The following is a description of a gene set: studied in species Mus musculus Mouse Gene Set: RAO_BOUND_BY_SALL4 Murine embryonic stem (ES) cells are defined by continuous self-renewal and pluripotency. A diverse repertoire of protein isoforms arising from alternative splicing is expressed in ES cells without defined biological roles. Sall4, a transcription factor essential for pluripotency, exists as two isoforms (Sall4a and Sall4b). Both isoforms can form homodimers and a heterodimer with each other, and each can interact with Nanog. By genomewide location analysis, we determined that Sall4a and Sall4b have overlapping, but not identical binding sites within the ES cell genome. In addition, Sall4b, but not Sall4a, binds preferentially to highly expressed loci in ES cells. Sall4a and Sall4b binding sites are distinguished by both epigenetic marks at target loci and their clustering with binding sites of other pluripotency factors. When ES cells expressing a single isoform of Sall4 are generated, Sall4b alone could maintain the pluripotent state, although it could not completely suppress all differentiation markers. Sall4a and Sall4b collaborate in maintenance of the pluripotent state but play distinct roles. Our work is novel in establishing such isoform-specific differences in ES cells. from publication Rao S, Zhen S, Roumiantsev S, McDonald LT, Yuan GC, Orkin SH (PMID 20837710) Loci bound by both isoforms (a and b) of SALL4 in ES cells (embryonic stem)., and this is the list of marker genes: Klf2, Vmn2r43, 1700019D03Rik, Vmn2r42 (NCBI Gene Id 22310), Gcm1, Zfp42, Idh1, Spry2, Map4k4, Mzf1, BC030500, Etfrf1, Tbx20, Fgfr1, Tpd52, Sema4b, Trp53, Mtmr12, Gtf3c6, Tmem64, Zfp27, Kifc3, Asns (asparagine synthetase), Myot, Rax, Slc39a14, Slc25a1, Or1j11, Wtap, Zcchc7, Rnf13, F2rl1, Kcmf1, Lmbrd2, Mob4, Ephx2, Tmprss11d, Slc5a1, D630039A03Rik, Vmn1r179, Insyn2b, Or10u3, Zscan10, Or4c31, Chd2, Fn1 (fibronectin 1), Susd6, Trim34a, Zdhhc14, Bcat1, Upp1, Hnrnpa2b1, Sf3b4, Cwf19l2, Jarid2, Aard, Srsf11, Nptx2, Cmklr2, Ccdc141 (coiled-coil domain containing 141), Zfp608, Nkx2-2, Cobl, Gpm6a, Prl7c1, Arnt, Xrn2, Aebp2, Tmeff1, Prdx6, Mib2 (mindbomb E3 ubiquitin protein ligase 2), Ssbp3, Wee1, H2bc11, Itga1, Rhob, Gjb3, Irf2bpl, Cep112, Klhl5, 2410137M14Rik, Insig2, Ywhag, Zfp182 (NCBI Gene Id 319535), Abt1, Hsd17b11, Zfp991, Reep3, Dkk1, Ptgfrn, Zfp704 (zinc finger protein 704), Adipor2, Tmem220, Sox2, Ubr5, Spic, Casq2, Arhgef18, Rptor, Trp53bp1, Sulf2, Ttc39b, Tlk1, Matr3, Chd7, H2ac22, Cfh (NCBI Gene Id 192290), Gcnt2, Aurkb, Ccn2, Uhrf2, Zc3hav1, Vmn2r34, Grsf1, Dgkh, Plin2, Gna13, Whamm, Syncrip, Fryl, Trim2, Usp48, Msantd2, Map10, Klhl34, Lyrm1, Zfp459, Abhd17b, Ccdc38, H2bc3, Fgd4, Vmn2r39, Ogt, Max, Vmn2r44, Pde1a, Slc38a2, Col4a2, Nbr1, Cpsf4l, Zfp280c, Zfp36l1, Zfp980, Exosc7, Prdm14, Ubl3, Stmn1, Mgat4c, Prss48, Gnpnat1, Zfp57, Fam91a1, Zwint, Parp6, Maco1, Stk38, Nolc1, Ifitm1, Jam2, Txlng, Akap12, Tm2d2, Mbtps2, Kdm2b, Eomes (NCBI Gene Id 97512), Il6st, Zic5, Spred1, Pdpk1, Sftpd, Eya1, Mycn, Or5w15, Vmn2r31, Nr0b1, Slc25a40, Fbxo36, Triml1, Gtf3c3, Hexb, Zfp532, Pyroxd1, Rybp, Smg7, Slco5a1, Flrt3, Ubb, Liph, Rab38, Fgfr2, Mapk1ip1, Pdgfc, Npepps, Atg14, Cidea, Tfcp2l1, Vegfc, Ddah1 (dimethylarginine dimethylaminohydrolase 1), H2ac7, Phc1, Map1b, Plekhg5, Pgap6, Stambpl1, Tfap2c, Fgfbp1, Epc2, Anp32a, Alg11, Bend3, Sec16a, Rest, Dusp6, Nefl, Sntb2, H3c3, B4galt6, Fgf4, Lrpap1, Serbp1, Pdhb, Lpar6, Arrdc3, Cyb5r1, Hexim1, Gja1, Rgs20, Cd24a, Dennd2c, Cst3, Tspan15, Slc44a1, Etv1, Dyrk3, Slc7a12, Zfp148, Nanog, Adam5, Slco4c1, Ldb1, Fbxo15, Trim25, Cacybp, Otx2, Tcl1, Dnmt3a